Given this list of marker genes Thrb, Akt2, Gdf6, Igf1, Dio3, Zfp110, Cln8, Pde6b, Grk1, here is a description of the gene set: species: Mus musculus Any apoptotic process in a retinal cell. Mouse Gene Set: GOBP_RETINAL_CELL_APOPTOTIC_PROCESS